The following is a description of a gene set: Mouse Gene Set: GOBP_MITOCHONDRIAL_TRNA_PROCESSING studied in species Mus musculus The process in which a pre-tRNA molecule is converted to a mature tRNA, ready for addition of an aminoacyl group, in the mitochondrion., and this is the list of marker genes: Elac2, Prorp, Rpusd4, Cdk5rap1, Mettl8, Trit1, Trmt10c, Trmt5, Mto1, Trnt1, Hsd17b10